Given this list of marker genes B2m, Psmc5, Psmc2, Ncf2, Psmd6, Psmc1, Psmb9, Psmb10, Itgb5, Psmd12, Psme2, Psma3, Psmd13, Vamp8 (vesicle-associated membrane protein 8), Psmb5 (proteasome (prosome, macropain) subunit, beta type 5), Psmd7, Psmc3, Psme1, H2-Q10, Ncf1, Psma5, H2-M10.6, H2-M10.1, Psmb7, Cd36, H2-Q7, Psmc6, Psmd1, Psma6, Psma4, Psmb4, Cd207, Cyba, Mrc2, Psma7, Psmc4, H2-M2, Psma1, Psmb8, Psmb6, H2-M10.2, H2-M9, H2-M3, Psma2, here is a description of the gene set: This event has been computationally inferred from an event that has been demonstrated in another species.<p>The inference is based on the homology mapping from PANTHER. Briefly, reactions for which all involved PhysicalEntities (in input, output and catalyst) have a mapped orthologue/paralogue (for complexes at least 75% of components must have a mapping) are inferred to the other species. studied in species Mus musculus Reactome Pathway: Antigen processing-Cross presentation electronically inferred by orthology from the curated human pathway part of: Class I MHC mediated antigen processing & presentation